Given this list of marker genes KIT, TET2, SCARB2, SRSF2, ASXL1, GBA1, CCND1, LIG4, here is a description of the gene set: species: Homo sapiens Multiple myeloma Human Gene Set: HP_MULTIPLE_MYELOMA A malignant plasma cell tumor growing within soft tissue or within the skeleton.